Given this list of marker genes KCNS1, FYN, GART, RAB10, KCNQ4, NPR3, NRG1, RBX1, CCL27, ESM1, KCND1, NEUROD6, SMAD1, RBFOX1, SOX5, MIER1, MECOM, NXPH4, DLG2, OTX1, DMD, ASIC1, PRKAG1, NIN, ZNF503, PRDM14, IRX6, LRR1, AMBP, HOXB4, NKX2-2, EXT1, UBL3, HEXIM2, FOXN3, PHOX2B, TSSK3, NTNG2, RPH3A, TMTC2, S100A10, RBM48, DRP2, RLF, ETV1, ZNF827, CLSTN2, BRINP3, ZBTB16, SLC38A6, STAG2, SFTPC, FAM3A, PDCD10, NOVA1, SPP2, EHF, TWIST1, C14orf132, TBC1D14, PLXNA3 (NCBI Gene Id 8276), MAG, GCK, EGR3, SERPINI1, NABP2, GAL3ST4, CAMK2D, MCF2, GRB2, AKIRIN2, PRRT2, MN1, KCNB2, NPNT, P2RX3, EMILIN1, INSRR, TCF7L2, GRB7, ADAM10, AK8, PATL1, HOXB2, RUNX1T1, SREBF2, HOXB1, SLC12A5, EYA1, LRMDA, LINC00173, PDE1A, SLC38A2, BBOF1, MGAT5B, ARL6IP1, NR2F6, FAM78A, BHLHE41 (basic helix-loop-helix family member e41), KCNH7, ROBO1, WNK1, TUBA4B, TMEM256, DNAJC11, SLC25A14, DTD2, KCNA1, LHX6, BARHL2, AASDH, DIO2, HOXC5, STAT5B, MYT1, CBX3, RTN4RL2, TIMELESS, DPYSL2, ZNF335, HNRNPA2B1, E2F8, NOG, TUBA4A, DNAI4, ALDOA (aldolase, fructose-bisphosphate A), SIX1, EIF4G2, POC1B, IFRD2, NUCKS1, DACT3, BTG1, OBSCN, NOL4, CDIN1, ING2, DLG3 (discs large MAGUK scaffold protein 3), PEX1, CELF4, NEGR1, NFIB, TBX3, CCN2, SERPING1, BRINP1, PRR35, REEP6, SMARCB1, JADE2, COL16A1, NTRK1, PIGP, MSI2, TAB3, DNAJB8, PFN2, DES, HOXA10, CALN1, KCNH2, ADCK1, TRPM7, SPACA9, TET2, RASGRF1, GATA4, SIAH3, DACH2, IKZF2, TLK1, EMP1, STMN2, ZNF644, ACVR2A (activin A receptor type 2A), CPNE6, GIT1 (NCBI Gene Id 28964), BTBD3, TRIB2, EYA4, HOXD10, TSHZ2, DPF1, CDH13, HOXA2, TBX6, C2CD5, JPH4, CCDC88A, KDELR2, LIN28A, C1orf21 (NCBI Gene Id 81563), IL1RAPL1, ATXN7L1, NFIX, RFX4, FCHSD2, WDPCP, MAX, CSMD3, HABP2, HNRNPA3, MOAP1, YWHAG, HNF4G, GRIK4, FBXW7, KMT2A, MEIS1, AEBP2, ST7, NR3C2, RAB33A, EEF1A2, STEAP2, RBM39, IL15, HAPLN1, KLF15, FGF8, VGF, SON, ZNF516-DT, GNB2, ITGA7, ZBTB9, GTF2A1L, TSGA10, PDZD2, CIB3, CBFA2T2, PLA2G15, DPP10, GALNT4, NOL4L, OSBPL7, CREM, TLX1 (T cell leukemia homeobox 1), here is a description of the gene set: Human Gene Set: CDPCR3HD_01 studied in species Homo sapiens Genes having at least one occurrence of the motif NATYGATSSS in the regions spanning 4 kb centered on their transcription starting sites. This matches the CUTL1 transcription factor binding site V$CDPCR3HD_01 (v7.4 TRANSFAC).